Given this list of marker genes Ppid, Gria2, Erdr1 (erythroid differentiation regulator 1, this gene is present on both X (Erd1x) and Y (Erd1y) chromosomes), Gnb1, Uqcrb, Snhg6, Actb, Zranb2, Hnrnpa2b1, Map2, Atp13a3, Lin7c, Matr3, Psmb5, Scn1a, Prkce, Ftl1, Kmt2e, Fos, Marchf7, Xist, Mobp, Sp3, Plp1, Ppp1cb, Steep1, Csrp1, Dynll2, Atp6v0b, Kif5a, Hint1, Glo1, Atp11a, Ankrd13c, Acsl4 (acyl-CoA synthetase long-chain family member 4), Dctn3, A4galt, Bbln, Kctd12, Syt1, Rabac1, Cadps, here is a description of the gene set: Neurologically relevant transcripts with highest abundance fold range in brain tissue among mouse strains. studied in species Mus musculus Mouse Gene Set: CHESLER_BRAIN_HIGHEST_EXPRESSION Patterns of gene expression in the central nervous system are highly variable and heritable. This genetic variation among normal individuals leads to considerable structural, functional and behavioral differences. We devised a general approach to dissect genetic networks systematically across biological scale, from base pairs to behavior, using a reference population of recombinant inbred strains. We profiled gene expression using Affymetrix oligonucleotide arrays in the BXD recombinant inbred strains, for which we have extensive SNP and haplotype data. We integrated a complementary database comprising 25 years of legacy phenotypic data on these strains. Covariance among gene expression and pharmacological and behavioral traits is often highly significant, corroborates known functional relations and is often generated by common quantitative trait loci. We found that a small number of major-effect quantitative trait loci jointly modulated large sets of transcripts and classical neural phenotypes in patterns specific to each tissue. We developed new analytic and graph theoretical approaches to study shared genetic modulation of networks of traits using gene sets involved in neural synapse function as an example. We built these tools into an open web resource called WebQTL that can be used to test a broad array of hypotheses. from publication Chesler EJ, Lu L, Shou S, Qu Y, Gu J, Wang J, Hsu HC, Mountz JD, Baldwin NE, Langston MA, Threadgill DW, Manly KF, Williams RW (PMID 15711545)